Given this list of marker genes SLC7A5, SLC43A1, SLC38A9, SLC3A2, SLC7A8, SLC43A2, here is a description of the gene set: studied in species Homo sapiens Human Gene Set: GOMF_L_LEUCINE_TRANSMEMBRANE_TRANSPORTER_ACTIVITY Enables the transfer of L-leucine from one side of a membrane to the other. L-leucine is 2-amino-4-methylpentanoic acid.